Given this list of marker genes B3galt6, Glg1 (NCBI Gene Id 20340), Tmed3, H2-Q7, H2-Q4, H2-Q1, Mob4, H2-D1, St3gal4 (ST3 beta-galactoside alpha-2,3-sialyltransferase 4), Tmem87a, H2-Q6 (NCBI Gene Id 636948), Chsy1, Golga2, Scfd1, Gorasp2, Fut2, H2-K1, Nsg2, Hid1, Gal3st3, Lyz2, Nucb1, Aph1a, Gcnt1, Yipf2, Inpp5e, Galnt2, Psenen, Yipf1, Gosr1, St3gal3, Galnt3, Sorl1, H2-Q2, St3gal1, Lyz1, Gal3st2, Atp2c1, Smpd3, Slc30a5, Cant1, Csgalnact2, Asap2, Golga5, Nsg1, Gpr89, Pitpnm1, Golga3, H2-Q10, A3galt2, Tmem115, Necab3, B4galt1, Rab21, Slc10a7, Arap1, Tmem87b, Nagpa, Uxs1, Sort1, Iigp1, Slc30a7, Fut4, Man2a1, St6gal1, Csgalnact1, 4930568D16Rik, Llgl1, Nucb2, Yipf6, Fut7, Sec1, Golt1a, Fut8, B4galt3, Rab34, Pld1, B4galt7, St3gal2, Sar1a, Galnt1, Sgms1, Tmed2, Lyset, Cog3, B4galt6, Hace1, Pcsk5, Chpf (NCBI Gene Id 98327), Furin, Xylt1, Ggta1, Bcap31, Golph3, Stx16 (syntaxin 16), B4galnt3 (beta-1,4-N-acetyl-galactosaminyl transferase 3), St6gal2, Sar1b, Hspd1, Acp3, Fut11, Bet1, Atl1, B4galnt4, B4galt5, Chsy3, Abo (NCBI Gene Id 80908), B4galt2, Cit, Tmem59, Golph3l, Fut1 (NCBI Gene Id 14343), Rab30, Golim4, here is a description of the gene set: Any of the thin, flattened membrane-bounded compartments that form the central portion of the Golgi complex. Mouse Gene Set: GOCC_GOLGI_CISTERNA studied in species Mus musculus